Given this list of marker genes SPRY2, CTSL, DUSP4, EGR3, IER3, HTR2B, IFI44L, PDE4D (phosphodiesterase 4D), SERPINE2, NR4A2, P2RY1, RSAD2, IRAK2, TPRG1, CLDN1, here is a description of the gene set: Human Gene Set: LEE_SP4_THYMOCYTE species: Homo sapiens from publication Lee MS, Hanspers K, Barker CS, Korn AP, McCune JM (PMID 15210650) To develop a comprehensive catalogue of phenotypic and functional parameters of human CD4(+) T cell differentiation stages, we have performed microarray gene expression profiling on subpopulations of human thymocytes and circulating naive CD4(+) T cells, including CD3(-)CD4(+)CD8(-) intrathymic T progenitor cells, CD3(int)CD4(+)CD8(+) 'double positive' thymocytes, CD3(high)CD4(+)CD8(-) 'single positive' thymocytes, CD3(+)CD4(+)CD8(-) CD45RA(+)CD62L(+) naive T cells from cord blood and CD3(+)CD4(+)CD8(-) CD45RA(+)CD62L(+) naive T cells from adult blood. These subpopulations were sort-purified to >98% purity and their expressed RNAs were analyzed on Affymetrix Human Genome U133 arrays. Comparison of gene expression signals between these subpopulations and with early passage fetal thymic stromal cultures identify: (i) transcripts that are preferentially expressed in human CD4(+) T cell subpopulations and not in thymic stromal cells; (ii) major shifts in gene expression as progenitor T cells mature into progeny; (iii) preferential expression of transcripts at the progenitor cell stage with plausible relevance to the regulation of expansion and differentiation of these cells; and (iv) preferential expression of potential markers of recent thymic emigrants in naive-phenotype CD4(+) T cells from cord blood. Further evaluation of these findings may lead to a better definition of human thymopoiesis as well as to improved approaches to monitor and to augment the function of this important organ of T cell production. Genes enriched in the single positive 4 (SP4) thymocytes compared to all other T lymphocyte differentiation stages.